Given this list of marker genes JAK2, IL12RB2, TBX21, STAT4, TNF, IL17A, GATA3, IL12A, IL2, STAT1, STAT5A, IL1B, IL12RB1, EBI3 (NCBI Gene Id 10148), IL27RA, IFNG, TGFB1, IL6, IL27, JAK1, IL6ST, STAT2, TYK2, IL12B, STAT3, IL18, here is a description of the gene set: species: Homo sapiens Human Gene Set: PID_IL27_PATHWAY from publication Schaefer CF, Anthony K, Krupa S, Buchoff J, Day M, Hannay T, Buetow KH (PMID 18832364) IL27-mediated signaling events